The following is a description of a gene set: Mouse Gene Set: GOBP_POSITIVE_REGULATION_OF_IMMUNE_EFFECTOR_PROCESS studied in species Mus musculus Any process that activates or increases the frequency, rate, or extent of an immune effector process., and this is the list of marker genes: Mavs, Xbp1, Gprc5b, Kmt5b, Il5, Tyrobp, Dhx58, Mif, Klrc2, Klhl22, Klrc1, Tap2, Slamf6, Cd177, H2-D1, Scimp, Tlr7, Il4ra, Lbp (NCBI Gene Id 16803), Cfp, Spon2, Socs5, Ccl2, Msh2, Stx7, 6030468B19Rik, Cd37, Mr1, Fgr, Pms2, Ffar3, Pomc, Cxcl1, Ulbp1, Lacc1, Ep300, Prkcz, Lilrb4a, Gpi1, Kit, Fcgr1, Trp53bp1, Btk, Pla2g3, Ighg2b, Cd81, H2-M3, Nod2, Mapkapk2, Adora2b, Il21, Crhr1, H2-K1, Tgfb1, H2-DMb1, Spi1, Il10, Klre1, Gata3, H2-M10.6, Crtam, Appl2, Tnfrsf4, Ffar2, Cd36, Itgam, Ankrd17, Ptprc, C3, Psg22, Rigi, Syk, Irf1, Hpx, Zbtb1 (zinc finger and BTB domain containing 1), Snx4, Rasgrp4, Arid5a, Pnp, H2-Q7, Foxp1, Rtn4, Il12a, Pycard, Card9, H2-T24, Pla2g5, Tek, Cd1d2, Ifng, Shld2, Pck1, Raet1e, B2m, Myo18a, Shb, Xcl1, P2rx7, Inava, Tlr2 (NCBI Gene Id 24088), Brd4, Sphk2, Il1b, Azgp1, H2-Q1, H2-M2, Rsad2, Il13, Colec11, Casp4, H2-T5, Rps19, Nlrp3, Gimap3, Il17a, Il33, Ddx1, Klk5, Dpp4, Fbxo38, Clcf1, Atad5, H2-M9, H60c, Sh2d1b1, Il13ra1 (interleukin 13 receptor, alpha 1), Opa1, Vamp8, Lag3, Htr2a, Mad2l2, H2-Q6, H2-Ea, Il1r1, H2-T15, Trem2, Ripk2, H2-M10.2, Cd1d1, Cd160, Tnf, Stxbp2, Fzd5, Tlr4, Traf2, H2-T13 (NCBI Gene Id 15027), Wnt5a, Cd46, Cd27 (CD27 antigen), Gata2, Pgc, Shld1, Foxp3, Cd300a, Tbx21, H2-M10.1, Ncr3-ps, Klri2, Casp1, Gimap5, Tnfrsf14, Pld2, Adora3, Arg1, Tlr9, Ddrgk1, Usp17le, Ap1g1, Clec7a, Ptafr, Nfkbiz, H2-T22, H2-M10.4, Fcgr3, Klrh1, Nppc, H2-M10.5, Lta, Ccr7, Nsd2, Cd40, Itgb2l, F2rl1, Pvr, Klrk1, Traf6, Ddx21, Nppa, Stat6, Enpp3, Hmces, Mir326 (NCBI Gene Id 723840), Cd24a, Exosc6, Cd28 (CD28 antigen), Sh2d1b2, H2-Q10, H2-Q2 (histocompatibility 2, Q region locus 2), Clnk, Hspd1, Nod1, Rasgrp1, Ephb2, Exosc3, Ptpn6, Il17f, Ighg1, Irf5, Gata1, Fer, Stxbp1, Klri1 (NCBI Gene Id 503550), Fcer1g, Malt1 (MALT1 paracaspase), Il2rg, H2-DMb2, Map3k7, Sash3, H2-M5, Nectin2, Lypd11, Ticam1, H2-Q4 (histocompatibility 2, Q region locus 4), Tnfsf13 (tumor necrosis factor (ligand) superfamily, member 13), Klrd1, Laptm5, Stat5b, Nfkbid, Paxip1, Il6, Ccl19, 2410137M14Rik, Mzb1, Ywhag, Ptpn22, Tlr3, Ms4a2, Sema7a, Stap1, Rbp4, Slamf1, Phb2, Klrb1c, Rara, Fcnb, Brd2, H2-T3, Fadd, Anxa1, Sh2d1a, Il2, Phb1, H2-M11, Kmt5c, Colec10, Shld3, Cd86, Il23a, Klk7, Nr4a3, Rif1, Cd74, Dennd1b, Klrc3, Myd88, Fcer2a, Fcer1a, Gab2, Il12b, Stx4a, Dnajb9, Sirt1, Vav1, Il18, Cd55b, Hspa8, Slc22a13, H60b, Mlh1, Tirap, Cadm1, Dhx36, Galnt2, Prkaa1, Cyrib, Il18r1, Il18rap, Tnfsf4, Zp3, H2-M10.3, Lypd10, Itgb2 (NCBI Gene Id 16414), Raet1d, Trim6, Pagr1a, Tfrc, Cd244a, Hk1, Mbl2, Hlx, Ddx60, Cd226, Lamp1, H2-M1, Plcg2, Cd55, Ccr2, Mir324, Stat5a, Il4, H2-T23, Panx1